Given this list of marker genes PRKCG, PRKCA, CDC37L1, ITGB3, FGB, STX4, SPARC, CLU, ACTN2, ITIH3, PLG, TUBA4A, VCL, BRPF3, LHFPL2, PDGFB, VEGFD, SELENOP, LAMP2, TAGLN2, PDGFA, SOD1, PPBP, TGFB2, PRKCB, FGA (NCBI Gene Id 2243), SERPINE1, HRG, HSPA5, CD9, AHSG, TGFB3, CLEC3B, GTPBP2, CTSW, SERPINA3, ORM2, TMX3 (thioredoxin related transmembrane protein 3), PECAM1, SPP2, TF, SRGN, OLA1, PPIA, LGALS3BP, CD36, TTN, CD109, GAS6, VEGFB, TOR4A, CHID1, VTI1B, F8, LY6G6F, FN1, POTEKP, ISLR, MAGED2, ORM1, ENDOD1 (endonuclease domain containing 1), WDR1, THBS1, FERMT3, ACTN1, RARRES2, KNG1, NHLRC2, MMRN1, SERPINA1, A2M, SERPINA4, SCCPDH, SYTL4, APP, ACTN4, FAM3C, VEGFA (NCBI Gene Id 7422), SELP, PFN1, CD63, CFD, SCG3, RAB27B, CAP1, PCDH7, TMSB4X, ECM1, HGF, STXBP3, ALDOA, IGF1, ALB, TGFB1, CYRIB, F5, PLEK, TLN1, CYB5R1, PF4, QSOX1, HABP4, FGG, CALM1, PSAP, APLP2, CALU, VWF, EGF, SERPING1, CFL1, PHACTR2, MANF, ITGA2B, IGF2, FLNA, LEFTY2, TIMP1, TIMP3, APOOL, APOH, VEGFC, ANXA5, APOA1, PCYOX1L, SERPINF2, ABCC4 (ATP binding cassette subfamily C member 4 (PEL blood group)), PROS1, A1BG, TEX264, ITIH4, F13A1, STXBP2, here is a description of the gene set: Reactome Pathway: Response to elevated platelet cytosolic Ca2+ Activation of phospholipase C enzymes results in the generation of second messengers of the phosphatidylinositol pathway. The events resulting from this pathway are a rise in intracellular calcium and activation of Protein Kinase C (PKC). Phospholipase C cleaves the phosphodiester bond in PIP2 to form 1,2 Diacylglycerol (DAG) and 1,4,5-inositol trisphosphate (IP3). IP3 opens Ca2+ channels in the platelet dense tubular system, raising intracellular Ca2+ levels. DAG is a second messenger that regulates a family of Ser/Thr kinases consisting of PKC isozymes. DAG achieves activation of PKC isozymes by increasing their affinity for phospholipid. Most PKC enzymes are also calcium-dependent, so their activation is in synergy with the rise in intracellular Ca2+. Platelets contain several PKC isoforms that can be activated by DAG and/or Ca2+. part of: Platelet activation, signaling and aggregation species: Homo sapiens